The following is a description of a gene set: Oral aphthous ulcers typically present as painful, sharply circumscribed fibrin-covered mucosal defects with a hyperemic border. Human Gene Set: HP_APHTHOUS_ULCER Aphthous ulcer species: Homo sapiens, and this is the list of marker genes: NLRP3, SLC19A1, SEC61A1, MEFV, ADA2, NOD2, SASH3, IL21, IL6